The following is a description of a gene set: studied in species Mus musculus The assembly and organization of an axoneme, the bundle of microtubules and associated proteins that forms the core of cilia (also called flagella) in eukaryotic cells and is responsible for their movements. Mouse Gene Set: GOBP_AXONEME_ASSEMBLY, and this is the list of marker genes: Ccdc65, Zmynd12, Odad4, Ift46, Ube2b, Rsph4a, Dnah5, Fsip2, Dnaaf10, Pdcl2, Dnaaf1, Tbc1d32, Cfap97d1, Cfap47, Foxj1, Cfap73, Dnaaf6, Drc1, Cc2d2a, Dnah8, Bbs2, Cplane2, Gas8, Spef2, Hoatz, Togaram1, Spag6l, Rp1, Dnai2, Drc7, Dnajb13, Ttll5, Zmynd10, Hydin, Cfap69, Cfap58, Ttll3, Spaca9, Dnaaf4, Cluap1, Rsph6a, Ulk4, Cfap100, Meig1, Odad2, Cep131, Ttll8, Pla2g3, Fsip1, Lrrc23, Dcx, Ift88, Dnah1, Cfap43, Dnaaf5, Rsph1, Spag1, Spag6, Cfap91, Dnah17, Dnai1, Dnaaf6rt, Lrrc61, Ccdc40, Clxn, Spag16, Neurl1a, Cfap65, Lrguk, Odad1, Mns1, Dnah7b, Pierce2, Dnaaf2, Cfap206, Tpgs1, Dnah7a, Ttll1, Cfap157 (cilia and flagella associated protein 157), Spef1, Lrrc46, Stk36, Ccdc39, Ak7, Jhy, Dnah7c, Dnaaf11, Dnaaf3, Dnal1, Ccdc103, Pierce1, Ttc12, Rp1l1, Ift56, Ccdc63, Cfap74, Armc2, Cfap57, Dnah2, Ofd1, Spag17, Fbxo24, Odad3, Dnai3, Cfap44 (cilia and flagella associated protein 44), Dnai4, Rsph9, Bbof1, Daw1, Tekt2, Iqcg, Tbc1d21 (TBC1 domain family, member 21)